Given this list of marker genes Tfrc, Vat1 (NCBI Gene Id 26949), Prkn, Oma1, Adck1, Mul1, Bnip3, Dnm1l, Huwe1, here is a description of the gene set: Mouse Gene Set: GOBP_NEGATIVE_REGULATION_OF_MITOCHONDRIAL_FUSION Any process that decreases the frequency, rate or extent of merging of two or more mitochondria within a cell to form a single compartment. species: Mus musculus